Given this list of marker genes MDH1, DDIT3, VSNL1 (visinin like 1), PDHA1, KPNA2, ASB2, MAP1LC3A, PGAM4, SLC2A1, IDH2 (isocitrate dehydrogenase (NADP(+)) 2), CLDN6, MACROH2A2, RSRP1, BEX2, CSRP1, UCHL1, TM7SF2, TXNDC17, MLLT11, SPINT2, MGARP, LIX1, FDPS, H2BC21, KRT18, FXYD7, SCG5, COA1, TPM2, CXADR, NAXE, RHPN2, TRH, IGFBPL1, PDPN, HACD1, KRT19, TMEM98, CDH3, TNNT1, MYRF, CKB, CTSV, SNHG17, PRDX2, SQLE, TNFRSF12A, ISYNA1, NHERF1, EMP2, ITGB1BP2, NME4, MGST1, LRRC49, GMNN, NEURL2, TMEM141, RASD1, CSRP2, RCAN1, NPPB, CALB2, NCCRP1, CXCL14, REC8, BZW2, ANXA3, CNN1, AMHR2, EZR, KLK6, HSPA5, HEY1, CRABP2, DMKN, ABRA, MSMO1, KRT8, CES1, KLK5, PARD6B, EIF3M, FDFT1, here is a description of the gene set: studied in species Homo sapiens from publication Cui Y, Zheng Y, Liu X, Yan L, Fan X, Yong J, Hu Y, Dong J, Li Q, Wu X, Gao S, Li J, Wen L, Qiao J, Tang F (PMID 30759401) Human Gene Set: CUI_DEVELOPING_HEART_C1_5TH_WEEK_CARDIAC_CELLS